The following is a description of a gene set: The chemical reactions and pathways involving aromatic derivatives of trans-cinnamic acid. Mouse Gene Set: GOBP_PHENYLPROPANOID_METABOLIC_PROCESS studied in species Mus musculus, and this is the list of marker genes: Cyp2a5, Cyp2a12, Cyp1a1, Cyp2a22, Cyp2a4, Pon3, Ugt1a8, Ugt1a7c (NCBI Gene Id 394432)